Given this list of marker genes Arhgap18, En2, Zbtb6, Nav3, Txk, Phf20, here is a description of the gene set: from publication Chen Y, Wang X (PMID 31504780) Mouse Gene Set: MIR_7682_5P species: Mus musculus Genes predicted to be targets of miRBase v22 microRNA mmu_miR_7682_5p in miRDB v6.0 with MirTarget v4 prediction scores > 80 (high confidence targets).